Given this list of marker genes Hadha, Echdc3, Auh, Ehhadh, Hacd3, Hacd1, Echs1, Hsd17b4, Hacd4, Hacd2, Cdyl (chromodomain protein, Y chromosome-like), here is a description of the gene set: studied in species Mus musculus Mouse Gene Set: GOMF_ENOYL_COA_HYDRATASE_ACTIVITY Catalysis of the reaction: a 3-hydroxy-fatty acyl-CoA = a enoyl-CoA + H2O. This reaction usually occurs in the reverse direction, leading to the reduction of the double bound of enoyl-CoA in position 2 or 3. Specific reactions catalyzed include: a 4-saturated-(3S)-3-hydroxyacyl-CoA = a (3E)-enoyl-CoA + H2O and a (3S)-3-hydroxyacyl-CoA = a (2E)-enoyl-CoA + H2O.